The following is a description of a gene set: Human Gene Set: ZHAN_VARIABLE_EARLY_DIFFERENTIATION_GENES_DN The vEDG down-regulated set: most variable early differentiation genes (EDG) with similar expression patterns in tonsil B lymphocytes (TBC) and multiple myeloma (MM) cells compared to the plasma cells from tonsil (TPC) and bone marrow (BPC). species: Homo sapiens from publication Zhan F, Tian E, Bumm K, Smith R, Barlogie B, Shaughnessy J Jr (PMID 12393520) To identify genes linked to normal plasma cell (PC) differentiation and to classify multiple myeloma (MM) with respect to the expression patterns of these genes, we analyzed global mRNA expression in CD19-enriched B cells (BCs) from 7 tonsils, CD138-enriched PCs from 11 tonsils, 31 normal bone marrow samples, and 74 MM bone marrow samples using microarrays interrogating genes. Hierarchical clustering analyses with genes clearly segregated the 4 cell types, and chi-square and Wilcoxin rank sum tests (P <.0005) identified 359 and 500 previously defined and novel genes that distinguish tonsil BCs from tonsil PCs (early differentiation genes), and tonsil PCs from bone marrow PCs (late differentiation genes), respectively. MM as a whole was found to have dramatically variable expression of EDGs and LDGs, and one-way analysis of variance (ANOVA) was used to identify the most variable EDGs (vEDGs) and LDGs (v1LDG and v2LDG). Hierarchical cluster analysis with these genes revealed that previously defined MM gene expression subgroups (MM1-MM4) could be linked to one of the 3 normal cell types. Clustering with 30 vEDGs revealed that 13 of 18 MM4 cases clustered with tonsil BCs (P =.000 05), whereas 14 of 15 MM3 cases clustered with tonsil PCs when using 50 v1LDG (P =.000 008), and 14 of 20 MM2 cases clustered with bone marrow PCs when using 50 v2LDG (P =.000 09). MM1 showed no significant linkage with normal cell types studied. Thus, genes whose expression is linked to distinct transitions in late-stage B-cell differentiation can be used to classify MM., and this is the list of marker genes: NAP1L1, DYRK1A, SRI, CCNB1, PSMD4, MARK2, GATD3, FXR1, ATIC, HADHA, SF3A3, SAFB, NUP160, ELF4, COX17, TBCB, CNN2, CDK4, ATP13A3, RABIF, BCL7B, PPP3CB, GNAI2, TOPBP1, SNX1, PSMC5, QARS1, VDAC1, CCT5, BTF3P13, FBL